Given this list of marker genes Trav7-6 (T cell receptor alpha variable 7-6), H2-Aa, H2-M10.1, Trav14n-1, H2-M10.4, Trav14n-2, Trav7-2, H2-DMb2, H2-DMa, H2-M10.6, Slc7a9, Trav15-2-dv6-2, Tap2, H2-Q2, Trav7-4, H2-T23, H2-T22, Trav14n-3, H2-M1, H2-T3, H2-K1, Maml1, Trbv29, 2410137M14Rik, H2-D1, H2-Q4, H2-M11, Trav14-2, H2-T13, H2-M10.5, H2-Ob, Tapbp, H2-Eb1, H2-T24 (histocompatibility 2, T region locus 24), Fcgrt, Trav7n-5, Trav14-3, H2-Ea, Trav14d-3-dv8 (T cell receptor alpha variable 14D-3-DV8), H2-M10.2 (histocompatibility 2, M region locus 10.2), H2-Q1, H2-T5, H2-Q7, H2-Eb2, H2-T10, Trav7-1, Trav14-1, Trbv1, H2-Ab1, Trav23, H2-M10.3, B2m, H2-M3, Tap1, Trav7n-4, H2-Oa, H2-M2, H2-M5, Trav7d-4, Trav7-3 (T cell receptor alpha variable 7-3), H2-M9, H2-DMb1, Trav7-5, H2-Q6, Dhcr24, Trav7d-6, Trav19, H2-T15, H2-Q10, here is a description of the gene set: Mouse Gene Set: GOMF_PEPTIDE_ANTIGEN_BINDING studied in species Mus musculus Binding to an antigen peptide.